The following is a description of a gene set: Catalysis of the reaction: substrate + ATP + CoASH = AMP + diphosphate + substrate-CoA. species: Mus musculus Mouse Gene Set: GOMF_COA_LIGASE_ACTIVITY, and this is the list of marker genes: Acsf2, Aacs, Acsl3, Acss3, Acsbg3, Acsf3, Acsm1 (acyl-CoA synthetase medium-chain family member 1), Acsm2, Slc27a2, Slc27a1, Acsl5, Acsl1, Acss1, Slc27a6, Acsm5 (NCBI Gene Id 272428), Acsl6, Slc27a5, Acsm4, Slc27a3, Acss2, Acsbg1, Slc27a4, Acsbg2, Acsm3 (acyl-CoA synthetase medium-chain family member 3), Dip2a, Acsl4